Given this list of marker genes DPM2, GALT, DOLK, DPM1 (NCBI Gene Id 8813), GALM, GNE, DPM3, GALK1 (galactokinase 1), PGM1, PMM2, NUS1, DHDDS, GFPT1, MPI, GALE, SRD5A3, here is a description of the gene set: studied in species Homo sapiens Human Gene Set: REACTOME_DISEASES_ASSOCIATED_WITH_GLYCOSYLATION_PRECURSOR_BIOSYNTHESIS Diseases associated with glycosylation precursor biosynthesis